The following is a description of a gene set: Cytokines mediate cell-cell communication in the immune system and represent important therapeutic targets. A myriad of studies have highlighted their central role in immune function, yet we lack a global view of the cellular responses of each immune cell type to each cytokine. To address this gap, the authors created the Immune Dictionary, a compendium of single-cell transcriptomic profiles of more than 17 immune cell types in response to each of 86 cytokines (>1,400 cytokine-cell type combinations) in mouse lymph nodes in vivo. A cytokine-centric view of the dictionary revealed that most cytokines induce highly cell-type-specific responses. For example, the inflammatory cytokine interleukin-1β induces distinct gene programmes in almost every cell type. A cell-type-centric view of the dictionary identified more than 66 cytokine-driven cellular polarization states across immune cell types, including previously uncharacterized states such as an interleukin-18-induced polyfunctional natural killer cell state. species: Mus musculus Genes negatively differentially expressed in cell type: CD4+ T cell upon treatment with cytokine: IL-5 in mouse lymph nodes in vivo. from publication Cui A, Huang T, Li S, Ma A, Pérez JL, Sander C, Keskin DB, Wu CJ, Fraenkel E, Hacohen N (PMID 38057668) Mouse Gene Set: CUI_T_CELL_CD4_IL5_RESPONSE_DN, and this is the list of marker genes: Jun, Hspa1a, Btg2, Junb, Hspa1b